The following is a description of a gene set: from publication Yevshin I, Sharipov R, Kolmykov S, Kondrakhin Y, Kolpakov F (PMID 30445619) Genes containing one or more binding sites for (BANP) in their promoter regions (TSS -1000,+100 bp) as identified by GTRD version 20.06 ChIP-seq harmonization. Human Gene Set: BANP_TARGET_GENES studied in species Homo sapiens, and this is the list of marker genes: MORF4L2, TCF3, GBF1, CCDC28A-AS1, MFSD8, MYSM1, MAD1L1, WBP1L, AKT1S1, SEPTIN7, COX7B, MIR933, PSMD9, THAP7-AS1, RBM39, CYB561D1, PSMD10, POLR2E, IMP3, SUPT5H, MOB1A, MGRN1, GTF2A1-AS1, IFT27, EDRF1, ZW10, FSIP1, ZNF79, PRR4, DNAJC27, TUBGCP6, RALBP1, SNX5, GGA1, DDX56, TMED7, ZFP91, MKKS, SPTY2D1, FKBPL, PPP1R15A, TRAPPC1, ZNF286A (NCBI Gene Id 93513), RPS9, TXNL1, HMOX2, HSBP1, AHCTF1, GOLGA8B, CDH13-AS2, ATP5F1C, UXT-AS1, SLC35B4, SBNO1, NSRP1, SRP19, SAP18, CDC5L, PIBF1, DHX37, TRA2A, TMEM245, ATG4A, TAB3, SMNDC1, DMXL1-DT (NCBI Gene Id 105379143), MICOS10, SSR4, EDEM3, ETV5, ZNF609, U2SURP, ENSG00000255647 (novel transcript), MTRF1L, RACGAP1, ADNP2, MAU2, WDR59, ITGB1BP1, TYW1, MAD2L1-DT, CIP2A, STXBP4, PRKAB1, DDX60L, SNRPC, CHUK, MRE11, MSH5, NDUFB6, MAP3K7, ZNF547, FAM76A, TAF1D (NCBI Gene Id 79101), GSK3A, TTC32-DT, DCAF6, PIK3R2, AGA, CCDC28A, TTC14-DT, MIR4482, RCC1, NAA35, RAMAC, PKIG, EIF3L, MED22, CETN2, ERICH6, MCCC2, PPOX, TSPYL1, MICOS10-DT, ERGIC2, RPS15A, SMARCD2, THAP9, UMAD1, FAM200B, SCAMP5 (NCBI Gene Id 192683), UPF3B, RPL17-C18orf32, ERCC6L2, SUPT16H, ATP5MC1, FDPS, PRPF19-DT, SF1, BANF1, PSPH, USP53, ABCF2, RAB33B, CDC20, RPS19, SNHG9, SCML1, STRIP1, ADAT1, SLC25A26, UBE2D3-AS1, RPA3 (NCBI Gene Id 6119), THTPA, SEC23B, RPL27A, KBTBD6 (NCBI Gene Id 89890), BLVRB, CERS5, RNPC3, ICAM4-AS1, SLC39A1, DIDO1, PPCDC, DFFA, CCT5, DNAJB4, TADA3, TMEM59, WDR27, DBR1, NPR3, HNRNPH3, ABHD18, NMT1, ZFHX4, CDK12, NUP37 (NCBI Gene Id 79023), PA2G4, ETFA, WDR73, TECPR1, FHL1P1, GRK4, ZKSCAN5, SAXO1, NDUFA11, SLC12A2-DT, ZNF416, PLSCR1, TIMM10B, XPC, ATP5PB, FANK1, MAK16, TRIM37, PROSER3, LINC01399, DCAKD, ZNF559-ZNF177, TERC, NOL9, SEC62, INKA2 (inka box actin regulator 2), SEC31A, MBTPS1-DT, VMP1, GORASP2, TTC23, HMBOX1, NMRAL1, TMCO1-AS1, XNDC1N, AKAP1, USP39, KIN, MARCHF7, RFC5, C6orf89 (NCBI Gene Id 221477), RPS15, STXBP5-AS1, SGSM2, GLCE (glucuronic acid epimerase), PIGN, SLU7, LTV1, RPS7, IKZF5, MED1 (mediator complex subunit 1), IL10, CBY1, SRCAP, DIS3, RIBC1, SMC4, PDRG1, UIMC1 (ubiquitin interaction motif containing 1), SKA3, HSPH1, POP7 (NCBI Gene Id 82671), NCOA4, CSDE1, NOP16, UFC1, MTR, UBE2D3, ETFDH, THUMPD3-AS1, NUDT2, HSPA4, NUDT19 (NCBI Gene Id 390916), MMS22L, CYB5D1, TRAPPC2B, CDC26, PIPOX, ASPH, PRPF19, MAPK14, RC3H2, HSF1, HSPB6, THAP7, VDAC3, BTN2A3P, GPR146, NOL11, ABI1, UBE2D2, CCNT1, CCT8, POLR1C, ENO4, GAS8, SC5D (sterol-C5-desaturase), NSUN3, NSDHL, TPD52L2, FGFR1OP2, CNTROB, MICOS10-NBL1, JOSD2, DNTTIP2, EMP1, CAMK2D, ARPC4-TTLL3, TP53, SPC25, RNF121, GTF2A1, ZDHHC5, LIM2-AS1, SETD5, PPIL3 (peptidylprolyl isomerase like 3), FUBP1, GCLC, GOLT1A, EXOC8, GPR19, SLX4IP, CD2AP-DT, HIBCH, PTGR2 (NCBI Gene Id 145482), RNF167, FAM135A, CPSF3, ASNSD1, AKAP1-DT, MRPL12, NFYC, ASXL1, CAB39L, HUWE1, LRSAM1, ATF2, SUCLG1, TROAP, TAOK1, ANAPC5, KBTBD6-DT, NECAP1, TMEM44-AS1, SMARCAD1-DT, PDE12, EEF1G, ADNP, MAGOHB, KIF3A, MDH2, RICTOR, WRAP53, SLC15A4 (solute carrier family 15 member 4), SNORD42B, CENPU, SRRT, COPS3, DDX19A-DT, SCAMP3, CIAPIN1, MTMR14, MSH5-SAPCD1, ANKFY1, CDC20-DT, SMG7-AS1, RRAGA, MAD2L1, EHD1, PCMTD1, PAXBP1, LINC03057, ADSS2, TMEM102, PNN, SMC1A, BTBD10, SIPA1L1, COQ9, RPL24, ABCC10, ARF3, LYRM7, TAS2R14, C5orf24, RPP38, AKAP11, TASOR2, RFC3, GGA3, UGGT2, SUGP1, DHX16, HBG2, MRPL42P1, TIPIN, TSPYL4, GDI2, IGSF5, IFT46, EPCIP-AS1, SNHG3, NANS, BZW1, MTFR1L, POLA2, CAND1, KPNA2, MGME1, HBE1, ZC3H12A, B2M, DGUOK, PSMD5, WDR44, RNPC3-DT (NCBI Gene Id 101928436), KSR2, TIMM22, FASTKD2 (NCBI Gene Id 22868), ZNF566-AS1, MDH1B, LUC7L2, TBCCD1, GPATCH3, ANKRD54, SMG7, SNORA78, ENSG00000248636, ULBP3, MRPS18B, VIPAS39, STK38L, ICAM5, PRH1, ZKSCAN2, NFIC, ZFC3H1, RNU12, MBTPS1, METTL2B, ZFHX2, DCTN2, EIF1AD, ATF7, CUL5, BBS5, SOWAHC, NCAPG, CKS1B, TP53RK-DT, ZNF346, SHC1, ALKBH2, KIF18B-DT, RBM15, RPPH1 (ribonuclease P RNA component H1), MIR3912, ZFHX4-AS1, PPP1R10, QRICH1, THAP1, TBC1D5, SLC12A2, KBTBD8, SNRNP70, RAPGEF6, DNAJB11, ZNF317, MRPS14, RMI1, RPL10A, EFHC1, SMARCAD1, PRPF4, NDUFA7, FAM216A (family with sequence similarity 216 member A), CCM2, MRPL57, WDR89, TRAPPC2, STYXL1, CDKN2D, RPL17, IFRD1, CDC6, DHFR2, POLDIP3, TMEM11-DT, ADISSP, CHAF1A, CCDC47, TCEANC2, PFKFB2, CLIC1, CNPY2, SEPTIN10, UHRF2, TMEM209, GID8, NUDT5, ATF4, ZNF219, IFT74-AS1 (IFT74 antisense RNA 1), RBPJ, BCAS3, SLC7A7, TUBGCP5, TAS1R1, AHSA1, SHPRH, THAP2, CREBZF, DDX3X, PIH1D1, ARPC4, INO80, COASY, MAFF, PABIR1, ESCO2, SMC1B, NKAP, NAA60 (NCBI Gene Id 79903), ERLIN2, CTB-30L5.1, ACADSB, HNRNPK, WDR6, PCMTD1-DT (NCBI Gene Id 124901944), ATN1, ASH2L, PATL2, METTL16, SVIP, ZNF559, SENP7, EIF4A2, CNNM2, ERCC6L2-AS1, TP53RK, ERICH6-AS1, ZFP91-CNTF, SRSF5, BCLAF1, CENPC, DRG1, PTPN4, WDR19, NOP58, PPP4R3B, RBM26-AS1 (NCBI Gene Id 100505538), DDX19A (DEAD-box helicase 19A), RPS28, SPTBN4, EXOSC10, CHURC1, WDR46, MPC2, NMNAT1, RPS11, MBLAC2, NOC3L, CCNH, TEX9, DENR, UBR3, EIF5, GTPBP2, CEP128, TMCO1 (NCBI Gene Id 54499), ENSG00000268129, NCL, COX11, BAALC-AS1, MICU2, PTPN1, SLC39A9, GIPC2, KIF18B, C1orf74 (chromosome 1 open reading frame 74), BUB1B, ZCCHC14, GMPPA, MRPS18C, SSR1 (NCBI Gene Id 6745), ACO2, PPP4R3B-DT, SUGT1-DT, PTGES3, PSMD2, RAB35-AS1, PXMP2, ZNF286B, EIF4A3, INTS13, ZNF827, CCNG1, GPBP1, CHUK-DT, EDRF1-DT, SNORD2, RTBDN, FAM111A-DT, LSM8, PEX11B, RSL24D1, RPL23A, SIL1, BAZ2A, LZIC, NOP14, RHOC, INTS9, ANKRD13C, BANP, PPP1R12A, LPXN, EIF5B, ZNF337-AS1, ZZZ3, CACYBP, CHURC1-FNTB, NAA38, TTC32, TMED7-TICAM2, FTO, RBM26 (NCBI Gene Id 64062), BDNF-AS, COPB2-DT, TARDBP, UPF3A, PURA, NUP133-DT (NCBI Gene Id 101927478), TMEM79, CCNC, GRWD1, RPL4, SETDB2, CCT6A (chaperonin containing TCP1 subunit 6A), RPS2, MATR3, RAB5C, FBXL5, LIN7C, NRBF2, EMD, SF1-DT, ENSG00000260830, OR51B5, CLP1, CEP350, DCAF16, FAM174C, IREB2, DZIP3, BRI3, LARS1, RPS3A, SNHG16, GSTO2, ATPSCKMT, CCDC77, LRRC28, SPRTN, RPS6, ZKSCAN2-DT, HCG14, C11orf54, FBXL19, PHF12, NANP, PPM1G, MTMR8, IDH3G, MAD2L1BP, TXNDC9, DNAJC27-AS1, SEPTIN7-DT, HCFC1R1, ZNF414, DSE, RIC8B, MTAP, CTDP1, THAP9-AS1, TMEM11, TMEM107, IFT80 (NCBI Gene Id 57560), SLC39A7, C4orf46, PFDN6, TTC14, WDR77, SMARCAL1, CLPTM1, YIPF3, CUL3, R3HDM1, MRPL52, SNRPG, LSM14A (NCBI Gene Id 91161), MIR4470, TMEM18, DNAAF11 (NCBI Gene Id 23639), TBC1D17, GPN3, HERC1, SLC25A11, GAS6-AS1, RPGRIP1L, CD2AP, AURKAIP1, ATF7-NPFF, TSR1 (NCBI Gene Id 55720), NPM1, POLE, ARFIP2, PRDX1, HELQ, RPL12, MORF4L2-AS1, WWOX, PUF60, TMEM183A, SMG5, PARPBP, DCAF11, ANKRD49, SMARCA5, RPIA (NCBI Gene Id 22934), USP54 (NCBI Gene Id 159195), PARP2, ZNF286A-TBC1D26, COPB2, LIN37 (NCBI Gene Id 55957), ZRANB3, THADA, ZWILCH, C6orf120, PHF5A, SPDL1, SEC22C, GNRHR2, RAB1B, GOLM2, DMXL1, RELCH, SRSF10, NKTR, NUDT19-DT, SNORD58B, RPL7A, POLR3G, ETF1, OFD1, IFT74, AGBL3, CENPT, MIR3667HG, TAF7, HOMER2, MAP2K2, MIR4734, RXRB, NFATC3, MTHFD1, ZNF566, DDX42, NKRF, TGOLN2, MRPS7, PTRH2, FZD6, FAM111A, RIBC2, GOLGA5, KIAA1191, SLC25A33, ENSG00000271860, CLPB, ANKRD13C-DT, RAB33B-AS1, YOD1, ACCS, ERH, FAM227A, PHB1, DARS1, RPL26, SUGT1, CDC123, SERBP1, GAN, POLR2B